The following is a description of a gene set: A specialized eukaryotic organelle that consists of a filiform extrusion of the cell surface and of some cytoplasmic parts. Each cilium is largely bounded by an extrusion of the cytoplasmic (plasma) membrane, and contains a regular longitudinal array of microtubules, anchored to a basal body. Human Gene Set: GOCC_CILIUM species: Homo sapiens, and this is the list of marker genes: GABARAP, PRKCI, MAPKAPK2, IFT57, ATP1B3, CCDC172, TCTN3, GARIN2, CFAP90, CFAP119, CDK5RAP2, LRRC23, TUBA4A, PPP3R2, MAP1B, TTLL4 (NCBI Gene Id 9654), KIF3B, CDKN1B, DNAI3, CC2D2A, TBC1D32, SEPTIN12, WDR35, CLNS1A, GALR3, DNAAF2, FBXL13 (NCBI Gene Id 222235), NAA11, CDKL5, OXCT2, CIBAR2, DYNLT2B, BUB1B, NMUR1, SNTN, RAB6D, SPMIP10, SEMA4D, POC1B, DNAH5, FSIP2, TCTN2, IFT52, DYNC2I2 (NCBI Gene Id 89891), DRC12, IGF1R, ATG14, HOATZ, MAPK3, C2CD6, WDR49, CCDC81, HIF1A, CFAP47, GALR2, TAPT1, CATSPER3, CEP290, SLC9B2, DNAL4, TUBA3E, LPAR3, CCDC38, ARL2BP, PAFAH1B1, MXRA8, C1orf115, RPAP2 (NCBI Gene Id 79871), KIF5B, ACTA2, TPPP2, SPA17, MARK4, CIMIP6, LYZL6, EVC, CFAP52, PMFBP1, PFKM, SRA1, ANKMY2, GRXCR1, IPMK, USP48, CKAP5, MICAL1, KNCN, KIF27, ACLY, RSL1D1, PRPH2, MAP4, FZD4, OPN1MW3, TUBGCP5, BRWD1, GLI1, CNTROB, GPR157, TRAF3IP1, MAPRE1, KLHL4, DEFB1, SPAG17, SEPTIN10, CFAP70, SMG6, PSMB7, STRC, ADAM15, AGBL4, CENPF, MICALL1, DYNLRB1, ODF2, ACTL7A, CIBAR1, PGK2, PDGFRA, ADCY9, TTC21A, NME7, CPLANE1 (NCBI Gene Id 84157), HYDIN, MAPK1, HSD3B1, DRD1, SMO (smoothened, frizzled class receptor), TNPO1, TRIP11, TUBA3C, CEP250, PSMB4, DYNLT4 (NCBI Gene Id 343521), CIMAP1B, DNAH14, KISS1R, RAB27A (NCBI Gene Id 5873), ABHD2, LRRC56, DISC1, RAB28, CATSPERZ, TEX55, HAVCR1 (hepatitis A virus cellular receptor 1), SLIRP, PEX6, EFCAB2, HAUS3 (HAUS augmin like complex subunit 3), TTLL2, PRKACB, CBL, IFT43, TMEM231, IFT27, PIP4K2A, FAM149B1, SNAP23, PCARE, PSKH1, ENTR1, MAPKAP1, ROPN1B, GAS2L2, C11orf42, EHD3, PDE6D, CFAP91, JADE1, RAC1, BCL3, CFAP77, ABCC3, EVC2, OPN1MW, DHRS3, IQCD, USH2A, DCDC2, CDKL1, DRC3, CATSPERB, TBC1D21, CSPP1, CATSPER4, ROPN1, FAM184A, USP26, EFCAB7, TSSK6, TMEM138, OAZ3, ELMOD1, CEP41, CFAP126, SPACA5, GUCA1B, PGAM4, ARFGEF2, QRICH2, SLC9C1, LRRK2, DIS3L, SNAP29, MCM2, RAB14, SYNE2, TTBK2, UNC119B, PIERCE1, CEP164 (NCBI Gene Id 22897), CEP104, CD52, PSMD10, TEKT3, CDHR1, LDHA (NCBI Gene Id 3939), PDE6B, CDH23, GLI3, CALM1 (NCBI Gene Id 801), CCP110, CABS1, CFAP144, TSGA10IP, CAV1, PPP2R3B, CFAP184, ATG7, RAB6B, CFAP263 (NCBI Gene Id 92918), ACE2, AJM1, ATP1A4, DNAI4, KIF19, TUBA1B, ODAD1, PPP2R3C, TEKT1 (NCBI Gene Id 83659), CEP126, CFAP96, TSSK3, SPATA6, AXDND1, CEP44, IFT88, DYNC2H1, STARD10, CEP170, PDIA6, FAM161A, CLCN4, ARMC9, NEDD9, DNAH12, RP2, CERKL, PKD1 (NCBI Gene Id 5310), NEK2, GNAT3, RIBC2, DRC1, TUBB4A, KIAA0753, NUBP2, TOPORS, CIMAP1A, STX3, MAPK15, STING1, GLIS2, TEKTL1, TACR2, PRKACA, ABCA4, TMEM262, CEP19, PRKACG, RSPH3, SPATA3, RSPH9, BRAF (NCBI Gene Id 673), CACNA1F, MAP4K5, TSC1, CCDC120, FLCN, HRAS, ATP6V1D, BSG, IFTAP, C11orf97, SPEF1, INVS, AK9, TMEM232, GNAT1, CABYR, NPHP1, TUBA3D, OPN1SW (opsin 1, short wave sensitive), CFAP68, BEST2, SLC1A5, KIF20B, CFAP100, GRK2, CHRNA3, IFT140, SNRNP200, ARL2, RPGR, ARHGAP35, RSPH10B2, SEPTIN4, RSPH6A, CCDC181, FSCB, PCDHB15, ODF1, SPAG6, TUBA1A, TACR1, FUZ, TP73, CFAP53, B9D1, POLA2, DNAJB13, IMPG1, GLI2, DYNLL2, CFAP74, MYOF, DNAH2, TSPEAR, DNAH8, CAMSAP2, ATXN10, SPAG5, ELMOD3, CFAP44, KIF3A, CCDC14, SEPTIN7 (septin 7), KMT5B, NME3, PCDHB13, ERC1, PCDH15, GNAI3, TAS2R46, SKA1, ADORA1, MACIR, AK8, TOGARAM1, DUSP3, ATG5, PSMC4, MERTK, SLC26A6, TSSK4, GPR88, ARL13A, RSPH1, PRKD3, PACSIN2, TAS2R4, NUP85, CFAP65, TTC23, AMBRA1, CCDC66, BBS2, ODAD2, PTGS1, ENKUR, EZR, INHA, TLE6, TUBA1C, HSPD1, NME5, NIN, DNAAF11, EPS15, NEK5, RAB11FIP3, CLXN, CBY1, ROPN1L, ARL6, DCDC2C, USH1C, KIF7, GPR19, CFAP161, NCAPD2, RSPH4A, CFAP73, SCNN1A (sodium channel epithelial 1 subunit alpha), ANO10, RAN, CCDC40, KCNJ10, CEP295NL, DNAH9, USH1G, CTNND1, VPS13A, CIMIP7, RP1, TAS2R43, PKHD1, CKAP2, HSP90AA1, CUL3, CNGA1 (NCBI Gene Id 1259), MNS1, ADRB2, KIF11, DNAH17, RPGRIP1, PRKCZ, BBS5, RNF38, PDZD7, TUBG1, GNAQ, CASK, IFT74, PCM1, DRD5, CNGB1, MYOC, HVCN1, RAP1A, NOTCH2, SPAG16, CDK20, DCTN1, PJVK, TUB, LUZP1, ENKD1, TSSK1B, P2RY1, PDCL, TTLL9, SPMIP4, OPN3, NXNL1, CST11, USP9X, WBP2NL, PRKAR2A, ATP1B1, LRRC46, DYNC2I1, CACNA1C, CCDC103, DAW1, RD3, EFCAB9, SMAD3, DLG5, EVI2A, CEP63, GRHL3, KLC3, GNAT2, SNTB2, PIERCE2, CFAP57, CKAP2L (cytoskeleton associated protein 2 like), FHDC1, HYLS1, MAGI2, CCDC39, KATNIP, SPMIP9, CALM3, CIMIP1, NPHP3, CETN1, AKT3, CATSPERD, CILK1, PROM1, CCDC42, DNAH10, PIK3C3, ALPK1, ROM1, DNHD1 (NCBI Gene Id 387750), TEDC1, RTTN, SMAD4, CADPS2, IFT172, ALMS1, KIF17, CEP20, IQUB, CDC45, ZMYND12, NECAB1, SCLT1, ANKS3 (NCBI Gene Id 124401), KIF5A, SPMIP8, SLC22A14, PIN1, ACAA2, GNA11, SLC25A31, TACC3, DNAL1, SEPTIN2, CC2D2B, GPRC5C, SPICE1, GK2, CNGA4, RABEP2, DNAI7, SEL1L2, GUCY2D, SLC26A8, EFHB, EFHC1, BAG3, CC2D1A, CCDC34, LRRC45, TULP2, SLC26A3, PCDH11Y, CROCC, PKD1L1 (polycystin 1 like 1, transient receptor potential channel interacting), IFT22, TACR3, CFAP107, OPN1LW, PPID, PDE6G, TOMM20, PRKAA2, PTK2, DLEC1, CATSPER1, DYNC2LI1, WDR11, CFAP206, PHYH, TOGARAM2, NEK1, CCDC61, TMEM218, NAXE, RPGRIP1L, CCDC65, PPP4R4, SPTBN5, SEPTIN9, RPAP3, TCP11X2, SAXO4, DYNLL1, PRKAR2B, SSX2IP (SSX family member 2 interacting protein), TTLL13, MAP1LC3B, CREB1, PDC, ADH1C, DLD, CFAP298, TULP3, RAB10, DRD2, CEP131, GUCA1C, CABCOCO1, CFAP43, RP1L1, SPAG8, MCHR1, MKKS (NCBI Gene Id 8195), AKT1, ADH1B, DZIP1L (NCBI Gene Id 199221), CEP152, TUBD1, BBS10, CETN3, FANK1, SAG, RRP7A, TPGS1, CFAP418, CFAP69, IFT20, RAB6C, ADCY6, PACRG, VCAN, HIPK1 (homeodomain interacting protein kinase 1), RIBC1, PPEF2, NEDD1, STRCP1, ARL3, SPHK1, GUCY2F, CIB2, GABARAPL1, TTLL3, BBS9, TMEM67, KIF3C, CNTRL, RAB34, CEP89, DNAAF5, CCDC178, GPR37L1, CPLANE2, MME, OCRL, CSNK1D, TTLL5, CIMIP2C, POC1A (NCBI Gene Id 25886), MAP2K1, TCEA2, SORD, RO60, RAB23, MARCHF7, DAAM1, GRK4, PDE4D, CEP128, TEKT5, HSD3B2, INPP5E, SUFU, EML4, IFT122, CBY3, FAN1, PRKAR1A, FZD6, NUBP1, RILPL1, CATSPERE, WDR54 (WD repeat domain 54), CCDC63, DNAH6, KCNU1, ATF3, EFHC2, TRPV3, KCNQ1, TUBGCP2, DUSP21, ODAD3, IQCE, ODF2L, SSX1, RUVBL1 (RuvB like AAA ATPase 1), TBC1D31, CALCR, OPN1MW2, CTSH, CLTB, TTLL7, SPACA3, MOK, CFAP58, UTRN, HHIP, CIMIP5, INTU, DZIP1, NME8, EHD1, TULP1, DNAH1, LDHC, WDR90, TBATA, CEP68, ARHGAP1, TCTN1, TMEM17, MROH2B, EGFR, MYRIP, DAPK3, HAUS7, TTLL11, CALM2, RILPL2, IQCB1, PRKCA, C2CD3, TXNDC15, CATSPERG, GNGT1, MAK, KIF2A, GLE1, RAB8A, TRPV4, SPACA5B, TMEM216, TEKT4, DNALI1, CAMSAP3, STOML3, MARCKS, CEP78, PHLPP2, GRK7 (NCBI Gene Id 131890), WDPCP, SPMIP6, DYDC1, GSTM3, TCP11, SMAD6, TSGA10, DRC7, ANKS6, NEK4, CSNK1A1, SHANK2, SPMIP5, CFAP46, PRKAA1, FBXW8, CFAP95, TTC8, OFD1, CYRIB, PRKAR1B, IFT46, RABL6, ATP1A1, ATP2B4, RSPH14, CIMIP2A, DNAH3, SPATA33, STIL, ZNF330, CIP2A, TMEM80, CENPJ, CLUAP1, UBXN10, SQSTM1, ARR3, PIK3R4, HTR7, SPMIP11, PROM2, PTPN23, CATSPER2, PSME3, PQBP1, CCR6, NPHP4, IFT80, SLC9B1, CHRM2, GUCA1ANB-GUCA1A, IFT81, AGBL2, TCP11X1, IRGC, TEK, PMM2, TMEM237, GPR161, NPY2R (NCBI Gene Id 4887), CCDC88A, CIMIP2B, CFAP20, ADGB, CCDC68, IFT56, TTC21B, AKAP14, ADCY3, SLC24A4, FHAD1, HDAC6, RAB3IP, DYNLRB2, CFAP45 (cilia and flagella associated protein 45), CRB1, CEP15, POGZ, VDAC2, AK7, CFAP276, CFAP210, IQCA1, GUCA1A, RSPH10B, AKAP4, CFAP36, CCSAP, SPAG1, CFAP300, KIAA1671, VCP, TBX3, RRM1, LYZL4, GNB1, MORN5, CCDC146, NPFFR1, WDR19, NPR2, B9D2, FLACC1, LZTFL1, HYAL3, LCA5, BMP2, TEKT2, PRPF6, CFAP251, MOSMO, BBS4, AKAP3, BBS12, RGS9BP, RABL2B, TCHP, CFAP141, PKM (NCBI Gene Id 8127), TTLL1, DDX6, IFT70B, RHO, WRAP73, CETN2, CIMIP4, SHANK3, OPN5, TBC1D30, CDC14A, GNAI2, DPYSL2, SPATA4, CNGA2, STK11, IL4I1, RAB11FIP5, LCA5L, HTR6, CFAP99, GPR83, CCDC50 (NCBI Gene Id 338335), PSEN1, EYS, DNAH11, CT55, SPATA7, WHRN, ADCY10, SSNA1, LYAR, BBS7, UMOD, TTLL8, LINC02914, PRLHR, GPI, SDCCAG8, PJA2, PKD2, POC5, EPB41L3, CFAP144P1, TUBB4B, DNAH7, KCNF1, CCDC170 (coiled-coil domain containing 170), CEP162, MLF1, CFAP54, PDE6H, SSTR3, SPEF2, SPACA9, NEK8, AK1, TTC29, CEP83, IL10RA, NFE2L2, SMAD7, ADH1A, ABRAXAS2, TBCC, TTLL6, CYLD, TBC1D7, FBF1, AHI1, SAXO2, PRCD, BBS1, CFAP61, CFAP410, VHL, SPAG4, PKD2L1, RAB15, KIF9, GAS8, FFAR4, CFAP157, SEPTIN6 (NCBI Gene Id 23157), TEKTIP1, KIAA1549, ULK3, SPATA19, ROBO1, IFT70A, OPN4, GNAI1, ERICH3, RAB6A, ANXA1 (annexin A1), DNAI2, RUVBL2, TGFBR1, CIMAP3, S100B (S100 calcium binding protein B), BBIP1, VPS37C, DNAAF1, RCVRN, DNAI1, KIFAP3, TCTE1, ADCY5, TMEM107, NAPEPLD, PDE6A, BBOF1, KIF5C, ARL13B, CDK10, CEP350, PSMA6, GRK1, NHERF1 (NHERF family PDZ scaffold protein 1), STAG1, PTCH1, CEP72, ATG16L1, TMEM249, IQCG, MAFIP, ODAD4, SAXO1, EFCAB6 (EF-hand calcium binding domain 6), CNGB3, AGTPBP1, KIAA0586, IFT25, CTNNB1, RAB37, TEDC2, CFAP221, MKS1, RILP (Rab interacting lysosomal protein), CCT8, MAP2, PDE4C, CYS1, NCBP2, PIBF1, AK2, PTCHD3, AURKA, MYO7A